Given this list of marker genes Ngf, Ngfr, here is a description of the gene set: part of: p75NTR regulates axonogenesis electronically inferred by orthology from the curated human pathway This event has been computationally inferred from an event that has been demonstrated in another species.<p>The inference is based on the homology mapping from PANTHER. Briefly, reactions for which all involved PhysicalEntities (in input, output and catalyst) have a mapped orthologue/paralogue (for complexes at least 75% of components must have a mapping) are inferred to the other species. species: Mus musculus Reactome Pathway: Axonal growth stimulation